The following is a description of a gene set: studied in species Mus musculus Mouse Gene Set: GOBP_PANCREATIC_A_CELL_DIFFERENTIATION The process in which relatively unspecialized cells acquire specialized structural and functional features of a pancreatic A cell. A pancreatic A cell is a cell in the pancreas that secretes glucagon., and this is the list of marker genes: Hes1, Rfx6, Onecut1, Insm1, Gata6, Pax6, Mir7-1, Nkx2-2, Nkx6-2, Neurod1, Nkx6-1, Vhl